Given this list of marker genes Grb2, Fgf2, Fgf9, Ppp2r1a, Fgf5, Fgf22, Fgf7, Fgf23, Fgf17, Ubc (ubiquitin C), Fgf16, Uba52, Cbl, Src, Ubb, Mapk1, Spry2, Rps27a, Ppp2ca, Fgf1, Fgf20, Fgf10, Mapk3, Fgf3, Ppp2cb, Uba52rt, Fgf4, Fgf18, Ptpn11, Frs2, Mknk1 (MAP kinase-interacting serine/threonine kinase 1), Fgf6, Braf (NCBI Gene Id 97330), Fgf8, here is a description of the gene set: Mouse Gene Set: REACTOME_NEGATIVE_REGULATION_OF_FGFR2_SIGNALING species: Mus musculus Negative regulation of FGFR2 signaling